The following is a description of a gene set: studied in species Homo sapiens Human Gene Set: MODULE_545 IL-1 signaling., and this is the list of marker genes: IL18R1, IL1RAP, DSCC1, CDH13, SERPINA5, UGT1A4, IL1RL1, VGLL1, ALPL, JAKMIP2, IL1R1, UBD, AKAP4, FOXF2 (NCBI Gene Id 2295), TLR2, GSTA2, HOXD9, HCRTR1, SOX30, DAO